The following is a description of a gene set: Human Gene Set: HP_REDUCED_TOTAL_NATURAL_KILLER_CELL_COUNT studied in species Homo sapiens The absolute count of natural killer cells in the blood, per microlitre, is below the lower limit of normal. Reduced total natural killer cell count, and this is the list of marker genes: PIK3R1, POLD3, IL2RG, SASH3, MAP3K14, PSMB9 (proteasome 20S subunit beta 9), IRF1, CD70, MCM4, CD3E, TOM1, B2M, DNMT3B, IKBKB, PTPRC, XIAP, GATA2, PGM3, PIK3CG, SYK, PIK3CD, ELF4, RIPK1, FCGR3A, KNSTRN, DCLRE1B, MCM10, POLD1, IL6ST, NLRC4, DOCK8, AP3B1